The following is a description of a gene set: from publication Szanto A, Balint BL, Nagy ZS, Barta E, Dezso B, Pap A, Szeles L, Poliska S, Oros M, Evans RM, Barak Y, Schwabe J, Nagy L (PMID 21093321) Genes up-regulated in bone marrow-derived macrophages with PPARG knockout treated with IL4: control versus rosiglitazone. Human Gene Set: GSE25123_IL4_VS_IL4_AND_ROSIGLITAZONE_STIM_PPARG_KO_MACROPHAGE_DAY10_UP Conditional macrophage-specific PPARg knockout mice were generated on C57Bl/6 background by breeding PPARg fl/- (one allele is floxed, the other is null) and lysozyme Cre transgenic mice. PPARg and IL-4 signaling was analyzed on bone marrow-derived macrophages. Bone marrow of 3 mice per group was isolated and differentiated to macrophages with M-CSF (20 ng/ml). 20 ng/ml IL-4 was used to induce alternative macrophage activation and 1 uM Rosiglitazone (RSG) was used to activate PPARg. From each mouse 4 samples were generated: 1. M-CSF, 2. M-CSF+RSG, 3. IL-4 and 4. IL-4+RSG. All compounds were added throughout the whole differentiation process, and fresh media was added every other day. Control cells were treated with vehicle (DMSO:ethanol). After 10 days, RNA was isolated and gene expression profiles were analyzed using Mouse Genome 430 2.0 microarrays from Affymetrix. studied in species Homo sapiens, and this is the list of marker genes: PISD, RBM42 (NCBI Gene Id 79171), TRIP13, LEFTY1 (left-right determination factor 1), TUBB4A (NCBI Gene Id 1864), HMGB1, IGLON5, WDR18, SMYD2, USP21, ANAPC10, NKG7, DAP, TACC3, LDAF1, CD19, LPAR5, MAST1, POLR1G, LRRC41, PCBD1, CLEC14A, SGK3, PIGL, SH3GLB2, GPR12, CCNH, PLOD1, UCK1 (NCBI Gene Id 83549), IL22RA2, ARMCX5, DSTYK, MSN, BSCL2, PGAM5, ARHGAP31, EI24, UTP4, PSME3, NRIP2, NUP62CL, PDXDC1, PELI3, TNXB (NCBI Gene Id 7148), GPM6B, PIGX, ART3, ARRB2, ID2, MYO1E, TRIM32, CLSPN, SNORD35B, KRTAP13-1, HAS2, POLR3E, CHMP2B, UBA2, GPATCH8, CCDC81, SLC18A1, CALHM5, PEG10, SNX15, RNF123, MYD88, SRFBP1, VLDLR, SERPINA12, TSEN34, IMPDH1, LCE1C (NCBI Gene Id 353133), ISOC1, NAGK, SPATA16, CPLX1, S1PR4, EIF1AD, MRPL36, RELT, SND1, PACS1, NAGA, SLC25A27 (NCBI Gene Id 9481), SNX27, BCKDK, NDUFA9, ACBD4, FBP1, ACSL6, DYNC2I1, ARHGAP11A, MAFG, BTK (Bruton tyrosine kinase), ADAR, EME1, INTS4, RWDD2B, PRC1, EXOG, FOXR2, MPI, CTTNBP2, DOP1B, MRPS14, MAGEA3, ACE, TOMM40, LSP1, EXOSC2, ADCY6, ECM2, BVES, ABHD14B, HGD (homogentisate 1,2-dioxygenase), BNIP3, SPECC1L, TUBA8, SUOX, RNF157 (NCBI Gene Id 114804), N4BP2L1, STX18, TTC21A, ADARB1, RPL3, MFHAS1, GTF2A1, NDE1, SPG11, CHRM3, LCN8, ARHGAP9, CCDC102A, PLXNB3, NKAIN3, ATP5MC1, TMCC1, FCRLA, ACP6, TBCB, GPT, NAGPA